The following is a description of a gene set: Human Gene Set: GOMF_PRE_MIRNA_BINDING species: Homo sapiens Binding to a precursor microRNA (pre-miRNA) transcript, a stem-loop-containing precursor of microRNA., and this is the list of marker genes: PRKRA, BCDIN3D (BCDIN3 domain containing RNA methyltransferase), TARBP2, TRUB1, DICER1, DHX36, RAN, XPO5, LIN28A